Given this list of marker genes UCP1, SCTR, BMP8A, TRPV1, OMA1, SCT, ADRB1, APPL2, ADRB2, ADRB3, TRPV4, SORL1, here is a description of the gene set: Human Gene Set: GOBP_DIET_INDUCED_THERMOGENESIS The process that results in increased metabolic rate in tissues of an organism. It is triggered by the detection of dietary excess. This process is achieved via signaling in the sympathetic nervous system. species: Homo sapiens